Given this list of marker genes CCT5, CCT8, CCT2, CCT7, CCT4, TCP1, CCT6A, CCT6B, ACTB, CCT3, here is a description of the gene set: Human Gene Set: REACTOME_FOLDING_OF_ACTIN_BY_CCT_TRIC species: Homo sapiens Folding of actin by CCT/TriC